The following is a description of a gene set: Human Gene Set: VISALA_AGING_LYMPHOCYTE_UP from publication Visala Rao D, Boyle GM, Parsons PG, Watson K, Jones GL (PMID 12618007) Genes up-regulated in peripheral lymphocytes from old individuals compared to those from young donors. Ageing results in a progressive, intrinsic and generalised imbalance of the control of regulatory systems. A key manifestation of this complex biological process includes the attenuation of the universal stress response. Here we provide the first global assessment of the ageing process as it affects the heat shock response, utilising human peripheral lymphocytes and cDNA microarray analysis. The genomic approach employed in our preliminary study was supplemented with a proteomic approach. In addition, the current study correlates the in vivo total antioxidant status with the age-related differential gene expression as well as the translational kinetics of heat shock proteins (hsps). Most of the genes encoding stress response proteins on the 4224 element microarray used in this study were significantly elevated after heat shock treatment of lymphocytes obtained from both young and old individuals albeit to a greater extent in the young. Cell signaling and signal transduction genes as well as some oxidoreductases showed varied response. Results from translational kinetics of induction of major hsps, from 0 to 24 h recovery period were broadly consistent with the differential expression of HSC 70 and HSP genes. Total antioxidant levels in plasma from old individuals were found to be significantly lower by comparison with young, in agreement with the widely acknowledged role of oxidant homeostasis in the ageing process. species: Homo sapiens, and this is the list of marker genes: FILIP1L (filamin A interacting protein 1 like), GNLY, CUX1, CSF1R, TMSB4X, KAT6A, TAF15